The following is a description of a gene set: studied in species Homo sapiens Human Gene Set: GOMF_PROTEIN_TRANSMEMBRANE_TRANSPORTER_ACTIVITY Enables the transfer of a protein from one side of a membrane to the other., and this is the list of marker genes: ABCA1, PEX2, PEX13, SEC63, AZGP1, TIMM17A, TOMM20, BLOC1S3, PEX14, SEC61A2, TIMM22, TIMM23B, SEC61A1, TOMM7, TOMM40, TIMM23, TOMM40L, TOMM70, SEC61G (NCBI Gene Id 23480), TMED10 (NCBI Gene Id 10972), MCL1, TOMM20L, TIMM17B, PEX10, TOMM22, PEX12, AP4M1